Given this list of marker genes SOX9, FANCC, RIN2, ITGB6, TWNK, NR0B1, MRPS7, BRCC3, CYP19A1, FANCB, GALT, PRORP, POLR1C (NCBI Gene Id 9533), AHSG, POLR3A, GNAS, NR5A1, CYP17A1, PMM2, SLC29A3, MRE11, FANCD2, DCAF17, ZBTB20 (zinc finger and BTB domain containing 20), WT1, MAP3K1, GATA4, POLA1, ZFPM2, CLPP, GALK1, FANCE, SRY, TYMP, DHX37, MGME1, POLG, FOXL2, POLR3B, NUP107, COQ2, LHCGR, MANF, WWOX, VAMP7, LEPR, LMNA, SQSTM1 (NCBI Gene Id 94002), CYB5A, LEP, BMP15, SAMD9, LIG3, RRM2B, FANCA, SIL1, LSS, CTDP1, SCP2 (NCBI Gene Id 6342), DHH, BMPR1B (NCBI Gene Id 658), AMACR, ALMS1, here is a description of the gene set: Reduced function of the gonads (testes in males or ovaries in females) associated with excess pituitary gonadotropin secretion and resulting in delayed sexual development and growth delay. Hypergonadotropic hypogonadism studied in species Homo sapiens Human Gene Set: HP_HYPERGONADOTROPIC_HYPOGONADISM